Given this list of marker genes Sri, Setd3, Rgs4, Fabp5, Scn5a, Dusp5, Prap1, Dsg2, Hamp, Smtnl1, Adrb2, Sgms1os1, Pdgfb, Inhba, Popdc2, Nr4a3, Nlgn3, Grin2c, Cacna1b, Qki, Akap6, Rapgef4, Atp1a2, Gpr39, Ager, Tshz3, Gal, Foxp1, Stk39, Mtpn, Gpr35, G6pd2, Nos3, Tnnt3 (troponin T3, skeletal, fast), Cacna2d1, Pex5l, Thrb, Ada, Parp1, Ptk2b, Kcna5, Tomm70a, Stx1a, Atpsckmt, Flna (NCBI Gene Id 245705), Adra2a (NCBI Gene Id 11551), Mmp2, Cbln1, Fgfr1 (fibroblast growth factor receptor 1), Mgll, Ddx39b, Tpm1, Rnf10, Cacna1c, Cux2, Cacng7, Hopx, Fgfbp3, Strit1 (NCBI Gene Id 102637511), Ccl3, Mstn, Hrh1, Pde9a, Gnas, Enpp7, Edn2, Ctnna3, Smad3, Myrf, Npvf, Tnfrsf21, Bves, Nos1, Gria1, Tac4, Gtf2ird2, Grin1, Prkag3, Hey2, Tmem25, Abl1, Shisa9, Npy2r, Igfbp5, Srl, Ptpn11, Nr3c1, Begain, Trim63, Hmgcr, Ndufs4, Trpc3, Ptger2, Abcg8, Mdm4, Nrxn1, Zc3h12a, Akt1, Zfp488, Tmem98, Eno1b, Cartpt, Kcnj5, Tmem38b, Gja1, Tafa4, Calca, Hamp2, Fgf12, Npy1r, Tnni1, Itgb1, Rbm10, Ep300, Cacnb3, Htr2c, Mc3r, Trpa1, Ehd3, Tnfrsf1a, Hgf, Dlgap2, Tead1, Mef2c, Pi16, Gdf1, Tenm4, Epb41, Trip10, Neurog1 (neurogenin 1), Lpin1, Gls, Gsk3a (glycogen synthase kinase 3 alpha), S100a1, Aqp1, Ccn3, Ttn, Cacna1g, Eif4a3, Fkbp1b, Npnt, Dock4, Hsp90aa1, Prkar1b (protein kinase, cAMP dependent regulatory, type I beta), Itgax, Arg2 (arginase type II), Icam1, Selenon, Tifab, Kcnip1, Nr4a1, Srebf1, Coro2b, Nppb, Gpr171, Fdps, Ucn, Camk2g, Htr2a, Thra, Cyp8b1 (NCBI Gene Id 13124), Kcnc4, Acvr2a, Tnnc2, Prkn, Adrb1 (NCBI Gene Id 11554), Myog, Atp2a1, Scn4a, Sox10, Tmem161b, Dock5, Mtnr1b, Drd4, Lif, Pclo, Cxadr, Ptger3, Neurod1, Gata5, Dsc2, Oprm1, Slc4a3, Pten, Cacna1h, Abcg5, Pik3r1, Trpv1, Grin2d, Homer1, Slc8a2, Kcnn2, Chrna7, Dmd, Or51e2, Dlg4, Abcc9, Nmur2, Cx3cl1, Ppp3ca, Ctsc, Faah, Asic2, Rock2, Isl1, Lep, Tbx5 (T-box 5), Oga, Nkx2-5, Irag1, Epas1, Slc22a5, Dag1, Wdr35, Phox2b, Ormdl3, Tnf, Ednrb (NCBI Gene Id 13618), Zfp418, Foxl2, Egr2, Hcn4, Hif1a, Lrp8, Runx1, Rangrf, Nrg1, Casq2, G6pdx, Foxo1, Kcne1, Myl4, Ucn2, Kcne5, Fgfr4, Adipoq (NCBI Gene Id 11450), Zmpste24, Alox5, Sp4, Bmp6, Anxa6, Kiss1, Atp2b4, Scn1b, Rock1 (Rho-associated coiled-coil containing protein kinase 1), Grcc10, Adra1a, Nlgn1, Pin1rt1, Grm3, Nup155, Agtr2, Tmem108, Adra1b, Shc1, Mlip, Hand2, Cacnb1, Kcnq1, Smtn, Mtg1, Rnls, Kcna1, Foxo3, Fxyd1, Svep1, Cav3, Mag, Crhr1, Kcne2, Adora1, Agt, Plk2 (polo like kinase 2), Acp3, Nrdc, Gucy1a1, Mtg2, Snta1, Cyp19a1, Tnfrsf1b, Trpm4, Fgg, Myocd, Tacr2, Fgb, Tbxas1, Th, Afdn, Atp2a2, Kcne4, S1pr2 (NCBI Gene Id 68430), Igf1, Gaa, Galr1, Lmna, Ffar3 (NCBI Gene Id 233080), Cldn15 (claudin 15), Adora2b, Fgf10, Cald1, Crhr2, Sema3a, Ryr2, Shox2, Cyp27b1, Baiap2, Tbx2, Slc25a12, Unc13b, Pin1, P2rx1, Nrxn2, Fig4, Zdhhc21, Irx5, Kcne3, Akap9, Dbn1, Prkcz, Dbh, Inhbb, Neto2, Abat, Tac1, Apoa2, Oxt, Gjc1, Nr1h2, Crhbp, Gba1, Adra2b, Stx1b (syntaxin 1B), Mir208a, Bmpr2, Apoe, Avp, Cacna1s, Pln (phospholamban), Ptgs1, Gpd1l, Mdm2, Hrc, Ttr, Mtmr2, Cc2d1a, Cntnap2, Fbxo32, Egfr, Scn10a, Kcnj8, Mymk, Stc1, Shank3, Npr3, Tnnt1, Scn4b, Glp1r, Gper1, Twf1, Chrm2, Kcnma1, Casr, Adm, Cdk9, Agtr1b, Cacnb2, Nfatc1 (nuclear factor of activated T cells, cytoplasmic, calcineurin dependent 1), Agtr1a, Lck, Il6, Sod1, Itga2, Npff, Htr1a, Kcnd3, Ren1, Mylk2, Pomc, Ctdp1, Smr2l, Nppa, Adm2, Rps6kb1, Cmya5, Atp5pf, Eif2ak3, Cacng1, Slc9a1, Glrx3, Jam2, Rnf207, Chrm3, Calm2, Myl3 (myosin, light polypeptide 3), Apoa4, Negr1, Cyp2j5, Ece1, S100b, Apoa1, Ahr (NCBI Gene Id 193333), Bin1, Pbx3, Shisa6 (NCBI Gene Id 380702), Edn1, Dicer1, Cav1 (caveolin 1, caveolae protein), Nkx3-1, Nherf1, Cacna1d, Acat2, Tmem100, Actn3, Map2k1, Celf4, Chrna2, Ntsr1, Klf4, Avpr2, Slc25a4, Kcnd2, Pak1, Dmpk, Cdk18, Grm1, Grip2, Tacr3, Apela, Sh3gl1, Irx3, Mybpc3, Crh, Gsk3b, Calcrl, Igsf11, Gtf2ird1, Grk2, Mef2a, P2rx4, Trpv4, Cry2, Gch1, Pirt, Sumo1, Hbegf, Tmem65, Uts2, Dab2, Camk2d, Arhgap42, Npsr1, Atp1b1, Eif4a3l2, Ssh1, Inha, Hrh2, Chrna3, Ednra, Slc1a1, Ptpn1, Tbc1d24, Rims2, Rims1, Slc22a21, Isx, Corin, Nlgn2, Fto, Ccn2, Hip1r, Homer3, Kcnip2, Errfi1, Src, Tspo, Tacr1, Becn1, Atp2b1, Retn, Stub1, Lpcat3, Prok2, Nos1ap, Smr3a, Chrnb2, Hcrt, F2r, Tlx3, Abcb1a, Kcnk9, Trf, Mtmr4, Scn2b, Adra2c, Cacng4, Wnt7a, Gja5, Gnao1, F2rl1, Akap1, Fmr1, Wasf3, Tppp, Cyba, Adcy10, Itga9, Grin2a, Ptafr, Smad6 (NCBI Gene Id 17130), Chrnb4, Tff2 (trefoil factor 2 (spasmolytic protein 1)), Adk, Grik1, Gnai3, Prkd1, Prkca (protein kinase C, alpha), Abcc8, Tnnc1, Prkg1, Pebp1, Mfn2, Fga, Shank1, Cacna1e, Nol3, Gjd3, Srebf2, Shisa7, Drd1, Nmu, Grin2b, Nppc, Mir23a, Glra1, Apln, Rgs2, Foxn4 (forkhead box N4), Zmynd8, Kbtbd13 (kelch repeat and BTB (POZ) domain containing 13), Cst7, Gas6, Hdac4, Eif4a3l1, Ecrg4, Tbxa2r, Sptbn4, Kdm5b, Nr1h3, Gsx2, Spp1, Ngfr, Sphk1, Csrp3, Eno1, Mtor, Ptpro, Smr2, Rab8b, Wnk1, Rhoa, Gdf9, Jarid2, Notch1, Kcnh2, Grik2, Avpr1a, Uts2r, Ryr1, Wnk3, Yy1, Adra1d, Pde4d, Cttn, Bmp10, Ptk2, Tnni3k, Cd38, Kit, Rem1, Neto1, Calm1, Pmch, Sgca, Nfatc3, Tnnt2, Flt1, Oprk1, Tbx18, Kcnj2, Spx, Add3, Ace, Inpp5k, Dvl1, Chrna5, Reln, Dgat1, Pde5a, Dlg1, Fgf13, Cysltr1, Nlgn4l, Rbfox2 (RNA binding protein, fox-1 homolog (C. elegans) 2), Ace2, Ank2, Gnai2, Ghsr, Parp2, Pard3, Wnk4, Htr7, Tmem38a, Tgfb2, Kcnh6, Myl2, Slc8a1, Aif1, Avpr1b, Cry1, Dsp, Myh6, Ccn4, Lrrk2, App (amyloid beta precursor protein), Kcnn4, Acacb, Lmcd1, Gata4, Agrn, Chga, Pawr, Ppara, Cldn2, Ncmap, Zfhx2, Ghrl, Casq1, Hnrnpk, Srf, Pkp2, Tnr, Myh7b, Edn3, Mecp2, Drd2, Ifng, Tnni3, Smad4, Slc8a3, Calm3, Gsn, Itga4, Jup, Atp1a1, Ptgs2, Tymp, Sirt1, Smad7, Pparg, Ptger4, Oxtr, Scn3b, Igsf9b, Emp2, Abcg2, Myh7, Vdr, C1qtnf1, Sct, Per2, Sln, here is a description of the gene set: Any process that modulates the frequency, rate or extent of a system process, a multicellular organismal process carried out by any of the organs or tissues in an organ system. Mouse Gene Set: GOBP_REGULATION_OF_SYSTEM_PROCESS studied in species Mus musculus